The following is a description of a gene set: studied in species Mus musculus This event has been computationally inferred from an event that has been demonstrated in another species.<p>The inference is based on the homology mapping from PANTHER. Briefly, reactions for which all involved PhysicalEntities (in input, output and catalyst) have a mapped orthologue/paralogue (for complexes at least 75% of components must have a mapping) are inferred to the other species. part of: Aerobic respiration and respiratory electron transport Reactome Pathway: Formation of ATP by chemiosmotic coupling electronically inferred by orthology from the curated human pathway, and this is the list of marker genes: Atp5f1b, Atp5pd, Dmac2l, Atp5po, Atp5pf, mt-Atp8, Atp5mc2, Atp5mk, Atp5mc1